Given this list of marker genes NR0B2, IRS2, IP6K3, NR1H4, BAAT, CYP8B1, RXRA, SLC10A1, CYP3A4, SLC27A5, FGF19, ABCB11, ABCB4, SULT2A1, CYP7A1, PPARGC1A, SLCO2B1, FKBP5, UGT2B4, here is a description of the gene set: Farnesoid X receptor pathway studied in species Homo sapiens Human Gene Set: WP_FARNESOID_X_RECEPTOR_PATHWAY